Given this list of marker genes RBM7, KHDRBS2, PATL1, AGO3, DDX60, PIWIL1, RBMS2, ILF3 (interleukin enhancer binding factor 3), PABPC4L, POLR2G, HMGB1, AGO4, DIS3L2, FXR1, RBMS1, SNRPC, LONP1, PABPC3, AGO2, ADARB2, PABPC5, STRBP, HNRNPDL, DDX11, DAZAP1, RIGI, PABPN1, PUS1, JMJD6, HNRNPH1, IFIT5, PABPC1L, EIF4B, PABPC4, PABPC1L2A (poly(A) binding protein cytoplasmic 1 like 2A), EIF4A3, LSM14A, PTBP1, SSB, FMR1, IFIH1, ZFR2, ZFR, PNPT1, HNRNPA1, AQR, PABPC1, ATXN1, DHX9, AGO1, U2AF2, MIR181C, HNRNPC, EIF4H, MSI2, DHX58, SRA1, ZCCHC13 (NCBI Gene Id 389874), ZC3H14 (zinc finger CCCH-type containing 14), TIA1, RBMS3, ENDOV, HNRNPF, LARP4 (NCBI Gene Id 113251), L1TD1, MCRS1, EXOSC10, DDX1, RBM11, DDX3X, HNRNPU, TLR7, DDX60L, DLX2, MIR9-1, MSI1, CBX4 (chromobox 4), CBX8, PPIE, A1CF, CNBP, LACTB2, IGHMBP2, KHDRBS1, CBX6, ELAVL4, PAN3, PABPC1L2B, TLR8, PABPN1L (NCBI Gene Id 390748), here is a description of the gene set: Human Gene Set: GOMF_SINGLE_STRANDED_RNA_BINDING Binding to single-stranded RNA. species: Homo sapiens